Given this list of marker genes Hspa1a, Dusp1, Fos, Hspa1b, Klf2, here is a description of the gene set: from publication Cui A, Huang T, Li S, Ma A, Pérez JL, Sander C, Keskin DB, Wu CJ, Fraenkel E, Hacohen N (PMID 38057668) Cytokines mediate cell-cell communication in the immune system and represent important therapeutic targets. A myriad of studies have highlighted their central role in immune function, yet we lack a global view of the cellular responses of each immune cell type to each cytokine. To address this gap, the authors created the Immune Dictionary, a compendium of single-cell transcriptomic profiles of more than 17 immune cell types in response to each of 86 cytokines (>1,400 cytokine-cell type combinations) in mouse lymph nodes in vivo. A cytokine-centric view of the dictionary revealed that most cytokines induce highly cell-type-specific responses. For example, the inflammatory cytokine interleukin-1β induces distinct gene programmes in almost every cell type. A cell-type-centric view of the dictionary identified more than 66 cytokine-driven cellular polarization states across immune cell types, including previously uncharacterized states such as an interleukin-18-induced polyfunctional natural killer cell state. Mouse Gene Set: CUI_CDC2_IL17A_RESPONSE_DN Genes negatively differentially expressed in cell type: cDC2 (conventional dendritic cell type 2) upon treatment with cytokine: IL-17A in mouse lymph nodes in vivo. studied in species Mus musculus